The following is a description of a gene set: Any process that activates or increases the frequency, rate or extent of leukocyte tethering or rolling. studied in species Homo sapiens Human Gene Set: GOBP_POSITIVE_REGULATION_OF_LEUKOCYTE_TETHERING_OR_ROLLING, and this is the list of marker genes: CCR2, FUT7, ST3GAL4, CHST2, GCNT1, SELP, ITGA4, CHST4, FUT4 (fucosyltransferase 4), SELE, ELANE